The following is a description of a gene set: Human Gene Set: MIR1245B_5P Genes predicted to be targets of miRBase v22 microRNA hsa-miR-1245b-5p in miRDB v6.0 with MirTarget v4 prediction scores > 80 (high confidence targets). from publication Chen Y, Wang X (PMID 31504780) species: Homo sapiens, and this is the list of marker genes: ZNF22, PPP3CA, HOXA9, IL17B, TAFA2, SPOPL, SLC17A5, DNER, SNAP47, KCNK13, BZW1, ARF6, CERT1, GID4, ABHD17B, BHLHE40, RNF38, ZNF74, NUP58, ZNF205, NEXMIF, DYNLT3 (dynein light chain Tctex-type 3), NUDT13, DERL2, SEH1L, PILRA (paired immunoglobin like type 2 receptor alpha), COL4A1, MED13L, TMPRSS3, ZNF584, MAP2, INSYN2A, CCDC85C, ZNF586, PPFIA1, SEC14L2, ARHGAP35, GRID2, MSANTD3, NMNAT1, ZNF367, ILDR2, BTBD1, SPARC, DENND11, SLC7A10, CASK, ZNF780B, PIP5K1B, MON1B, SCG2, DENND6A, KLHL29, ZNF781, SLC24A2, ZNF773 (zinc finger protein 773), ADRA2A, CDC14A, NAA30, ITGB1BP1, TRAF3